The following is a description of a gene set: A quatrefoil tethering complex required for retrograde traffic from the early endosome back to the late Golgi and biogenesis of cytoplasmic vesicles. studied in species Homo sapiens Human Gene Set: GOCC_GARP_COMPLEX, and this is the list of marker genes: EIPR1, VPS52, VPS51, VPS53, VPS54 (NCBI Gene Id 51542)